Given this list of marker genes TREM2, EHD1, PCSK9, LIPA, ABCC8, GPLD1, ADIPOQ, MIR27B, LDLRAP1, APOC1, MIR33A, IL19, LPL, HNRNPK, APOB, FGF21, APOM, APOA2, LMF1, HMOX1, MIR302A, NR1H4, MIR17, MIR133A1, MIR128-1, CNPY2, LIPG, APOA1, MIR96, KHSRP, SCARB1, LRPAP1, APOE, MSR1 (NCBI Gene Id 4481), MYLIP, MIR185, MIR379, VLDLR, COMMD1, SOAT2, APOC3, LDLR, APOA5, CD36, CSK, MIR199A1, NCEH1, ITGAV, MIR223, MIR148A, MIR144, MIR27A, SOAT1, APOC2, MIR33B, CES3, ITGB3 (NCBI Gene Id 3690), ANXA2, GPIHBP1, LIPC, DGAT2, here is a description of the gene set: Human Gene Set: GOBP_PLASMA_LIPOPROTEIN_PARTICLE_CLEARANCE studied in species Homo sapiens The process in which a lipoprotein particle is removed from the blood via receptor-mediated endocytosis and its constituent parts degraded.